Given this list of marker genes Serpinb6b, Acp4, Ptpn3, Pml, Hipk2 (homeodomain interacting protein kinase 2), Epha4, Ufsp2, Sirt4, Spink12, Usp5, Usp19, Ctsz, Clec16a, Alad, Trim39, Cstdc6, Thbs1, Fmr1, Svip, Serpinb6e, Ins1, Phf20l1, Stfa2l1, Usp7, Serpinb9h, Pabpn1l, Serpinb13, Spink1 (NCBI Gene Id 20730), Gapdhrt2, Usp17le, Wfdc6a, Styx-ps, Tlk2, Wac (NCBI Gene Id 76331), Ccar2, Mtm1, Furin, Stfa1, Gapdhrt, Glg1, Pdcl3, Rps7, Cstdc5, Rybp-ps, Cdh1, Prmt6, Gapdh, Shh, Marchf7 (NCBI Gene Id 57438), Serpinb1a, Serpinb9c, Caml, Tmem98, Il10, Usp25, Snx12, Klhl40, Tm4sf20, Psme3ip1, Taf9, Gapdh-ps15, Sufu, F8a, Cdk5, Serpinb9g, Cln3, Akt1, Ttc36, Ide, Timp2, Ddrgk1, Usp14, Ogt (NCBI Gene Id 77137), Usp9x, Timp1, Gabarapl2, Senp1, Bag6, Serpinb1b, Psen2, Hfe, Plat, Nop53, Uchl5, Prkcg, Rab23, Sgta, Serpine1, Gipc1, Serpinb6c, Rpl11, Eif3h, Usp26, Spink5, Ubxn1, Cstb, Rpl5, Anks1, Serpina5, Serpinb10, Ophn1, Csta3 (cystatin A family member 3), Ppp1r15a, Il1r2, Rybp, Kng2, Nr1h3, Bag5, Wfikkn1, Timp3 (tissue inhibitor of metalloproteinase 3), Nr1h2, Kng1, Stfa2, Cpb2, Stfa3, Usp38, Cstdc3, Serpinb9, Styx, Vtn, Gas1, Serpinb8, Serpinb9e, Cst7, Serpine2, Timp4, Spink2, Park7, Hsp90ab1, Qrich2, N4bp1, Hdac6, Psmf1, Ins2, Pbk, Lrrk2, Csta1, Csta2, Reck (reversion-inducing-cysteine-rich protein with kazal motifs), Psen1, Cdkn2a, Fetub, Spink6, Lrig2, Cst3, Tmed10, Serpinf2, Ubxn2a, Ecm1, Serpinb6d, Csnk2a2, Aqp11, Crb2, Serpinb6a, Sco1, Chac1, Trp53, Serpinb1c, Fhit, F2, Serpinb9f, Spock3, Serpinb9b (NCBI Gene Id 72011), Wnt1, Map1a, Plau, Mdm2, Ctla2a (NCBI Gene Id 13024), Smarcc1, Cast, Serpinb9d, Pik3r1 (NCBI Gene Id 328326), Lamp3, Csnk2b, Bin1, Rpl23, Eppin, Spock1, Cstdc4, Efna1, here is a description of the gene set: Any process that stops, prevents, or reduces the frequency, rate or extent of the hydrolysis of a peptide bond or bonds within a protein. Mouse Gene Set: GOBP_NEGATIVE_REGULATION_OF_PROTEOLYSIS species: Mus musculus